The following is a description of a gene set: Human Gene Set: HP_ABNORMAL_RENAL_TUBULAR_EPITHELIAL_MORPHOLOGY studied in species Homo sapiens Abnormal renal tubular epithelial morphology Any structural anomaly of the renal tubular epithelial cells (RTEC), a layer of cells in the outer layer of the renal tubule. These cells play a role in the absorption of substances such as glucose and amino from the primary urine., and this is the list of marker genes: MUC1, NPHP3, NPHP1, CEP83, NUP133, MYO1E, VPS33A, NPHP4, CLCN5, VPS33B, GLIS2, TMEM67, ITGA3, REN, UMOD, RPGRIP1L, XPNPEP3, NUP107, NPHS1